Given this list of marker genes RANBP9, RCHY1, MAP6D1, GPR137B, TRIB3, PUM2, ARAP2, SMARCD3, SLC12A7, TRIB1, ZFAND3, MKRN1, ZNF200, DENND4A, SEC62, PIP4K2C, ASAH1, PLEC, CARMIL1, ABCC4, WAPL, TMC6, EMC7, SEC22A, FAM171A1, LINS1, HPGD, PDZD8, GVINP1 (GTPase, very large interferon inducible pseudogene 1), EBAG9, RBBP5, FBXO46, USP12, STAG1, JUNB, CEP192, ZNF274, UBTF, RPL13A, TM2D1, ICE1 (NCBI Gene Id 23379), NDST2, MFSD1, NFRKB, ZMYND8, TMEM185B, KDSR, MBD1, RPS15A, IGF2BP3 (NCBI Gene Id 10643), PIK3IP1, CLCN3, SCYL3, P2RX5, TRIOBP, TVP23B, IER2, ING1, THUMPD1, GRAMD2B, BNIP3, TMEM50A, SPTLC1, APOBEC3G, AFTPH, PIM2, ASPSCR1, ZDHHC18, PPP3CA, IL6ST, KRAS, CYBC1, ANAPC10, PAPOLG, SPSB1, MCF2L, MPPE1, STAT6, PHYH, TMEM131, TBL1X, CDR2, PRRC2B (proline rich coiled-coil 2B), MARCHF3, HSD17B11, BIN2, MINPP1, TMBIM4, LRIF1, BFAR, GRB10, FBXO21, PTPN4, PLEKHO2, NAA60, RPIA, CD247 (CD247 molecule), BIRC3, MFN1, CSK, SLC39A14, COQ10B, SIAH1, CTC1, EPHA4, PPM1B, IL27RA, SNX29P2, TAX1BP1, PRMT2 (NCBI Gene Id 3275), RDH11, PDP1, CD53, RAB4B, MALT1, ACVR1, UBE3B, TRIB2, PFDN5, CALCOCO1, OBI1, ASTE1, PPP2R5E, B4GALT7, MT1F, RAB29, GTDC1, RAB7A (RAB7A, member RAS oncogene family), DUSP11, ITGAL, LPIN2, FAM89B, EXT2, DERL2, PDE3B, TRAF3 (TNF receptor associated factor 3), S100A10, VPS16, ZFYVE16, ENTR1, LY75 (NCBI Gene Id 4065), ACTR5, VAV3, SPINK2, AHCTF1, LSM14A, GOLGA7, ANTKMT, PIK3CB, TLL1, ESYT1, PDE9A, CFP (NCBI Gene Id 5200), RWDD3, GPR18, OSBPL8, SLC30A1, DGKZ, TMEM14B, PAPOLA, IMPACT, IL32, PSMD5, TMEM43, PJA1, ZNF292, ENGASE (NCBI Gene Id 64772), KDM6B, JMJD1C, MCL1, ZBTB18, NLRP1, TSPYL1, DUSP10, ZNF24, RAB33A, KLHL36, RSAD2, CD38, ZC3HAV1, ARHGEF4, ELK4, ATP8A1, ZNF14, PCBP4, MLYCD, TM9SF3, RAB3GAP1, KAT2B, CCNT2, SLC39A6, PIBF1, PPP2R5A, DOP1A, NEU1, S100B (NCBI Gene Id 6285), FLT1, FABP7 (NCBI Gene Id 2173), PLAAT4, TM2D3, here is a description of the gene set: from publication Hervas-Stubbs S, Riezu-Boj JI, Gonzalez I, Mancheño U, Dubrot J, Azpilicueta A, Gabari I, Palazon A, Aranguren A, Ruiz J, Prieto J, Larrea E, Melero I (PMID 21108462) Human Gene Set: GSE17301_CTRL_VS_48H_IFNA2_STIM_CD8_TCELL_UP IFN alpha mediated gene expression pattern. The effect of IFN alpha on human CD8 T cells responding to antigen (signal 1) and costimulatory signals (signal 2) provided by beads coated with anti-CD3 and anti-CD28 mAbs. This analysis examined the effects of IFN alpha on human CD8 T cells responding to antigen (signal 1) and costimulatory signals (signal 2) provided by beads coated with anti-CD3 and anti-CD28 mAbs. Magnetically sorted untouched CD8+CD45R0- T cells from three different donors were unstimulated or stimulated with IFNa2b or with anti-CD3/CD28 Beads alone or along with IFNa2b or IFNa5 for 48 hours. Individual mRNA samples were analyzed using HG-U133A 2.0 array gene chips. Genes up-regulated in CD8 T cells: control versus stimulated by IFNA2. species: Homo sapiens